Given this list of marker genes FOXD1 (forkhead box D1), HES5, IRX2, PAX2, IRX1, OSR1, PAX8, IRX3, here is a description of the gene set: Any developmental process that results in the creation of defined areas or spaces within the kidney to which cells respond and eventually are instructed to differentiate. species: Homo sapiens Human Gene Set: GOBP_PATTERN_SPECIFICATION_INVOLVED_IN_KIDNEY_DEVELOPMENT